Given this list of marker genes HLA-DRB1 (major histocompatibility complex, class II, DR beta 1), PSMB8, FGFR2, BTNL2, TP63, CXCR4, LYN, SHARPIN, ATP2A2, TCOF1, here is a description of the gene set: Any abnormality of the parotid glands, which are the salivary glands that are located in the subcutaneous tissues of the face overlying the mandibular ramus and anterior and inferior to the external ear. species: Homo sapiens Abnormal parotid gland morphology Human Gene Set: HP_ABNORMAL_PAROTID_GLAND_MORPHOLOGY